Given this list of marker genes Castor2, Sesn3, Sec13, Szt2, Castor1, Mios, Seh1l, Wdr59, Sesn1, Sesn2, Wdr24, here is a description of the gene set: A multiprotein subcomplex of the GATOR complex that regulates TORC1 signaling by interacting with the Rag GTPase. In human, this complex consists of WDR24, WDR59, MIOS, SEH1L, and SEC13. In S. cerevisiae, this complex is referred to as SEACAT and contains the Sea2p, Sea3p, Sea4p, Seh1p, Sec13p proteins. studied in species Mus musculus Mouse Gene Set: GOCC_GATOR2_COMPLEX